The following is a description of a gene set: species: Homo sapiens from publication Chen Y, Wang X (PMID 31504780) Human Gene Set: MIR6800_5P Genes predicted to be targets of miRBase v22 microRNA hsa-miR-6800-5p in miRDB v6.0 with MirTarget v4 prediction scores > 80 (high confidence targets)., and this is the list of marker genes: CLN5, LVRN, ADAMTS5, ATP5MC3, TTC14, ABHD12, MANEA, MTUS1, CHMP3, IFIT5, EPS15, ADAP1, TNIP2, UBAP2 (ubiquitin associated protein 2), ANXA4, SLC38A2, LIPH, SUGT1, ZNF614, MMP3, DDX46, MNAT1, QKI, NIT2, RAVER2, NAT1, GOT1, LNPEP, TM2D2, PNPLA3 (NCBI Gene Id 80339), ANKRD12, BBOF1, MYO16, ARHGAP24, EPHA6, RNF103-CHMP3, GLO1, NEK7, SPRED3, ZNF785, KRT222, PTPRZ1, PCDH9 (protocadherin 9), DIS3